The following is a description of a gene set: The directed movement of substances along cytoskeletal fibers such as microfilaments or microtubules within a cell. studied in species Homo sapiens Human Gene Set: GOBP_CYTOSKELETON_DEPENDENT_INTRACELLULAR_TRANSPORT, and this is the list of marker genes: TRAK1, IFT46, KIF16B, BLOC1S6, KIF3B, PAFAH1B1, RHOT1, HIF1A, SPAG17, MAP6, IFT172, DYNC2LI1, KIF28P, WASL, SYBU, IFT81 (intraflagellar transport 81), CDR2L, AP3D1, AP3S1, KIF13A, APBA1, FUZ, FLOT2, MYO10, DYNLL1, SNAPIN, TUBB, RASGRP1, MAP2K1, DYNC2I1, BORCS7, IFT25, FEZ1, BBS12, TUBA1A, TMEM201, KIF21A, RAB21, RABGEF1, IFT70A, IFT27, TRAF3IP1, IFT20, HSPB1, SOD1, ATG5, CCDC88A (coiled-coil domain containing 88A), SPAST, COPG1, BICDL2, MAP1A, RPGR, TUB, MAPT, NETO1, LCA5L, TRIM46, CDC42 (NCBI Gene Id 998), RAB27B, FBXW11, DYNC1I1, WASF1, BICD2, HOOK1, DTNBP1, HNRNPU, CCDC186, RUFY4, TUBA1B, F8A3, STAU2, AP3M1, SYNE2, IFT57, PPFIA2, AP3S2, TERF2, CEP131, KIF17, TTC21A, ACTN4, MAK, HOOK2, AGTPBP1, BORCS6, MAPK8IP3, F8A2, IFT43, FNBP1L, MYO1C, IFT70B, TRAK2, UCHL1, PRICKLE1, KIF1B, HTT, BLOC1S5, INTU, KIF5A, MAP2, NDEL1, UXT (NCBI Gene Id 8409), APP, CCDC88C, BLOC1S4, DLG2, HOOK3, SUN1, SUN2, BLOC1S3, PCM1, MYO5A, SFPQ, KIF4A, IFT122, NEFL, RAB1A, IFT22, COPG2, BLOC1S2, MAP6D1, DAW1 (dynein assembly factor with WD repeats 1), MYO19, IFT140, STAU1, CCDC38, MAP1S, NME7, F8A1, KIF3A, FYCO1, BLOC1S1, RAB17, NEFH, AP3M2, NDE1, SPG7, DYNC1H1, KIFAP3, ACTR10, IFT74, CCDC88B, ARMCX3, IFT80, TANC2, ARL8A, TRIM58, LCA5, KIF5B, MREG, UBB, TMEM108, HDAC6, CAMSAP3, DCTN1, ARL3, KXD1, BORCS8, HAP1, BAG3, KIF1A, BICDL1, DST, TTC21B, LRPPRC (leucine rich pentatricopeptide repeat containing), WDPCP, ATG16L1, RUFY3, ARHGAP21, RAB6A, SYT4 (synaptotagmin 4), KIF5C, MGARP, STK11, ARL8B, CILK1, IFT88, CLN3, BORCS5, DYNC1I2, DYNC2I2, KLC3, CLUAP1, WDR19, KIF1C, OPA1, BICD1, SSX2IP, PURA, SSNA1, PEX14, WDR35 (NCBI Gene Id 57539), RHOT2, IFT52, AP3B2 (NCBI Gene Id 8120), IFT56, TMEM230, CLIP3, HSBP1, AGBL4, AP3B1, LAMP1, RABL2B, SPG11, DYNLT2B, MAP1B, KIFBP, DYNC2H1, KIFC2, TUBA1C